Given this list of marker genes WDR11, SORCS2, SLC25A12 (NCBI Gene Id 8604), AUP1, UNC119, RAB3B, IL6, SRI, SLC18B1, KCNK1, VPS35L, SLC12A2, GHRHR, SLC1A2, SEC23B, CHMP2B, SLC6A15, YBX1, GIPC1, SLC49A4, SNX17, SLC6A11, SLC22A1, CHRM5, SP100, SLC11A1, LMTK2, TGFBR2, GCK, ADCY8, FAM53A, SCAMP2, AIFM1, PAM16, COG5, HTR2C, RAB11B, RGPD3, SLC25A31, ARL11, FOXA2, UQCC2, RPGR, KLHL20, WASHC2A, TARDBP (TAR DNA binding protein, NCBI Gene Id 81927), PRKCD, CENPF, RAB15, HEATR5B, NMD3, LIN7B, MIA2, EXOC4, RAMP1, SLC35A4, MTCH2, KPNB1, VIPAS39, SIX3, UBE2G2, RAB3D, REST, AIMP1, LRP5, ATP1B1, SAR1A, SLC25A18, EP300, SACM1L, RAB6C, RAB8A, FGB, CETN2, VPS39, SLC25A17 (NCBI Gene Id 10478), B3GAT3, SLC43A2, ACHE, RBM22, NEAT1, BEST1, MYRIP, HERPUD1, SMO, SLC38A6, SYT1 (NCBI Gene Id 6857), SELENBP1, PCK2, IFT56, GIP, VAMP2, GCKR, OAZ3, YIF1B, GCC2, CDKN2A, SLC16A10, NEUROD1, SLC7A6, LONP2, IPO7, AKTIP, NASP, SLC25A29, RANBP6, SNX32, BBS7, SMG1, MON1B, TOR1A, RBM8A, TRPM5, SLC52A3, JUP, EXOC7, MX2, SLC7A11, CHMP5, RAB11FIP5, VGF, CALHM4, TNFSF11, RAB11FIP3, ADRA2B, CRHR1, KIF3B, GLUD1, ARL5B, RABGEF1, AP1G2, LILRB1, APBA1, SMG7, FFAR4, PLEKHA8P1, RABL2B (NCBI Gene Id 11158), TMED1, NCOA4, RAB3IL1, ACVR2B, PRKN, NXF5, DENND1B (NCBI Gene Id 54530), TAP1, FMR1, GJA5, FRAS1, RBSN, VAMP4, SLC51B (NCBI Gene Id 123264), CHML, SLC25A25, STRADB, CDK5, HSPA4, AQP6, ORAI1, VTA1, MTNR1B, SLC7A1, PDPN, RAB8B, IGF2BP2, DOP1A, NPY2R, TMED5, RFTN1, PSAP, SNX7, SNX3, MYH10, GHRH, XPO1, KCNJ10, COG1, TRIM28, AP1B1, MCOLN1, STX18 (syntaxin 18), PANX1, F2R (NCBI Gene Id 2149), VMP1, MVP, ZDHHC2, SLC19A2, RBM33, NUP37, MIR130B, CNST, PCNT, SNX21 (sorting nexin family member 21), C17orf75, ZW10, ANK2, ARF1, NUP214, GDI2, ILDR2, PRKCE, FAM3D, GOLGA4, COPZ1, STX7, SARNP, OPRM1, ABCG2, UCN, ZFAND2B, NECAB3, NEURL3, MYO7A, QKI, MLPH, ARFGAP2 (ADP ribosylation factor GTPase activating protein 2), GPR89A, TMED2 (NCBI Gene Id 10959), RAB6B, ARL17B, ELAVL1, MAFA, RGPD1, SFXN3, AHCYL1, NHERF1, ARL3, OXCT1, SLC7A3, MVB12A, SLC23A3, SLC9B2, TMED3, TIMM10, SERINC3 (serine incorporator 3), RAC1, CNIH4, TRAM2, SLC6A3, MCOLN2, ARHGAP1, RAB14, RINT1, ITGB3, SEM1, SEC62, ZC3H12A, LARGE1, DUOXA1, EIF4A3, S100A13, APOE, HBA1, TOMM20, TANGO6, LYPLA1, JAKMIP1, PEG10, PER2, POM121L2, SLC9A4, GAPVD1, IPO5, RHBDD1, SYK, FYTTD1, NTSR1, LRRC8D, GRIPAP1, NXF2B, STX17, NUP98, AKAP8, EXOC2, POM121B, ZFYVE16, TSPO2, VPS45, DNAJC14, TGFB3, MTX1, NOS1, SLC6A6, SLC35A1, TBC1D17, PSEN1, MON1A (MON1 homolog A, secretory trafficking associated), FAM91A1, VPS13A, OAZ1, HERC2, CTNS, EXOC8, MGST1, RHCG, KCNB1, SLC25A53, B4GALNT2, TXN, KDELR1, MIR199A1, SLC38A8 (solute carrier family 38 member 8), TGFB1, KIF20B, RBP4, STX1B, TNPO2, SUFU, NXF2, NAGPA, UBAC2, GLTP, STX16, CCDC93, PLA2G3, AACS, TMED10, SLC1A5, SLC25A20, SLC6A9, TIMM21, MIR29B1, TREM2, TRIM23 (NCBI Gene Id 373), PDCD6IP, HTR1A, ECRG4, AGAP1, PLEKHF2, SAA1, SLC35C1, P2RY1, WASHC2C, MAPK15, CHRNA4, CTAGE9, CHMP4B, TERT (telomerase reverse transcriptase), ITPR1, ADAM8, NUP160, FOXO1, PEX19, FERMT1, TUNAR, TUBA1A, TCN1, XPO6, SLC38A2 (solute carrier family 38 member 2), FGG, CAMK1, TFR2 (transferrin receptor 2), EXOC6 (exocyst complex component 6), PEX1, MTM1, DDX25, ATG3, PAX8, CLEC4M, ZC3H11A, PFKM, RAB39A, HDAC6, SLC25A51, ISL1, HLA-DRB1, SEC16A, EXOC6B, ADORA3, C2CD2L, VPS51, IFT25, SLC7A6OS, RAB41, MYO1D, DRD3, MIR199B, UHMK1, RAB11FIP2, RAN, TMEM167A, TMEM129, PLA2G1B, APBA3, PPP3CA, CALHM5, ZIC1, SCG5, VPS26A, SPRN, HNF1B, DRD2, TLR4, ATF2, VPS16, RGS4, MIR128-1, STX10, TRMT10B, ATP8A1, ANGPT1, ACTN4 (actinin alpha 4), COPG2, SLC38A9 (solute carrier family 38 member 9), WASHC5, TOMM40, SYT11, E2F3, SLBP, SNX14, PRP4K, CETN3, TOMM5, TOM1L1, TNF, PARK7, SLC7A8, ABCB7, SLC28A1, HBB, VPS41, CLSTN3, VPS29, SLC17A2 (solute carrier family 17 member 2), TRIP11, SLC6A8 (solute carrier family 6 member 8), IPO8, TIMM17A, LRRC8A, CHRNA6, RHAG, NF1, AFG2B, UPF2, ATP13A4, DERL1, SIRT3, THOC5, EMD, SLC5A7, ADRA2C, CASR, SLC15A1, AMN, LRP2, INS, DENND2A, MMP7, ARFGAP3, CD24, SLC18A2, TVP23B, TRPM4, MIDN, SLC28A3, SLC23A1, KHDRBS1, TMED7, SLC25A23, KPNA3, MYH9, HNF1A, SLC7A9, ZC3H11C (zinc finger CCCH-type containing 11C), MDM2, NEURL1B, EXOC1, OPRK1, NR1H3, DRD1, PPID, CCDC186, GRK2, SLC36A4, LYN, GNA11, RAB27B, SLC29A1, SNUPN, SLC16A12, TNPO3, VPS37C, IL10RA, MAMDC4, CRH, ACSL3, NAPA, KIF5A, CD320, TPR, BBS1, TMEM30A, FUT10, RANBP3L, ACSL4, PPARG, GPM6B, SNCG, AP3S1, RAB44, VAMP7, ATG4C (autophagy related 4C cysteine peptidase), DYNLT1 (NCBI Gene Id 6993), UFM1, KRT20, BBS2, CAV1, AP3B2, SNX25, GOPC, RTN2, NUP54, PCSK5, NTRK2, AKAP5, VPS54, ABCA13, VPS25, CORO7, MFSD1, GNAO1, FGF9, SCARB2 (scavenger receptor class B member 2), AP3S2, SUCNR1, DERL3, CHCHD4, SLC16A1, RPH3A, SLC44A2, KPNA5, CDK1, COPB2, ARF4, SLC1A7, RD3, LCA5, SUPT6H, PKD1 (polycystin 1, transient receptor potential channel interacting), PLCB1, ERP29, KPNA4, TGFBRAP1, ARHGEF2, SLC35B3, TOMM70, RAMP2, PHAF1, FXR1, AP3M2, COL1A1, ABCC2, SLC25A38, SPTBN1, SLC3A2, NOTCH1, RAB3GAP2, PKIG, RAB12, AP2A2, SYT4, EXOC3L1, WASHC4, ATXN2, ABCC6, DNAJC19, GNPTG, UPK3A, SYNDIG1, ARFGEF2, GRP, CAMSAP3 (NCBI Gene Id 57662), CCDC22, HEATR3, APP, NNAT, RAB29, NACA2, TIMM29, SNX27, AGFG1, COPB1, TESC, FFAR3, SPG11, RAB4B, RABGAP1L, CEP290, SLC16A9, ARC, NKX6-1 (NCBI Gene Id 4825), CHMP1A, SLC7A5, HSPB1, ACTB, ARCN1, RTRAF, RGS2, SIX2, FRMD4A, CHGA (NCBI Gene Id 1113), APBB1, CLN8 (CLN8 transmembrane ER and ERGIC protein), ATG10, MACIR, ARL4C, PGAP1, BLOC1S3, CLTRN, DTNBP1, SCRIB, BTK, COMMD1, PEX2, SPIRE2, RAB32, CBLN1, SLC22A16, ZG16, STX8, CFTR, RIC1, SFT2D3, WASHC3, SH3TC2, CTTN, GOSR2, ABCA1, EDNRB, SCAMP4, IST1, FLNA, CHM, IL13, SYNRG, PTPRN2, TMEM115, BTF3, ASPH, ARL6IP1, GAL, MDFIC, ARL4D, SEPTIN8, EHD1, NUP62CL, SLC25A52, POM121C (NCBI Gene Id 442581), PEX6, VEGFC, PDX1, SYTL1, CLTA, GRM1, SNX15, SLC36A3, DHX9, NOS2, PPM1F, ATP11A, ATP2C1, GGA1, SEC24C, BBS9, AQP3, CALR, RAB1A, GNAI1, AZGP1 (NCBI Gene Id 90053), TAF7, LLGL2, PTPN1, DNAJC27, CXCL12, NPY5R, IL1B, SLC46A2, PRF1, NUP153, CD33, SNX11, CTAGE15, STXBP1, ATP6AP1, SLC25A19, HSPA5, MAP1A, CERT1, HPSE, SLC25A36, ARL8A, INHBB, P2RX7, RFTN2, ATP8A2, SPAG17, DISP1, CD200, SLC19A1, TMEM97, IFIT1, GCG, KCNN4, FGF20, TRPC4 (NCBI Gene Id 7223), AP1M2, AP2M1, LRSAM1, PDE8B, SLC35A3, GRPEL1, ABCD2, SHOC2, FLOT1, SNX8, RAE1, HIKESHI, ATG4A, RAB19, PRKCB, BET1, CALHM2, FCER1G, JAK2, ABCC5, PCM1, PKDCC, RAB26, RAB4A, CBLIF, GPR119, COG7, RILPL1, CBLN4, EDNRA, DUOXA2, ZFP36L1, HMGA2, RILP, SLC52A2, SLC4A8, ERC1, CHMP4C, RAB36, TGM2, SYTL2, PTPN23, PEX5L, DERL2, SLC38A1 (solute carrier family 38 member 1), CSF2, MIR146A, CR1, KLF7, COPA, MC4R, NEDD4, SCG2, SORL1, STXBP2 (NCBI Gene Id 6813), PEX12, PEX26, TSG101, MIR30C1, COG3 (NCBI Gene Id 83548), CASC3, RAB6A, CLIP3, CRHBP, SNX30, NACA, CALHM1, SLC26A6, ZFAND1, DGKD, ADCYAP1, ABCA12, NR4A1, VPS33B, IL33, MAPK14, TSC2, RAB28, SLC22A15, NEO1, ALKBH5, TM7SF3, ABCC1, HYAL2, VPS8, RAB10, RAB39B, GPER1, TRPV4 (transient receptor potential cation channel subfamily V member 4), STX3, MIR19B1, CHMP2A, FAM3B, SCAMP3, USP9X, ARFIP2 (NCBI Gene Id 23647), CYB5R4, EHBP1, SLC22A4, EXOC3, C2CD5, DNAJC15, GOLT1A, SORT1, NBAS, VPS18, RAB5A, GABBR1, KPNA7, RAB11FIP1, DNAJC1, SEC61A2, ADIPOQ, ABRA, NUP42, SETD2, PAFAH1B1, SNX5, HSPA8, UMOD, RAB7A, GOLPH3L, RANBP2, RCN3, COPZ2, RAB38, ZFP36, SLC1A3, PFKFB2, SLC35D1, KCNA5, SMG5, PORCN, WNK1, SQSTM1, SURF4, TRPV1, ARFIP1, SYS1, CTAGE4, AGK, RAB2B, SLC25A41, KCNK16, NDP (NCBI Gene Id 4693), KIF17, CHMP3, NUP50, EPM2A, GNAT1, VPS37A, CDKN1A, MLXIPL, STAT3, SLC25A24, GRIP1, SLC14A1, NPIPA1, PRKG1, COMP, NR1H2, YOD1, COG2, GFER, HIP1, ENSA, GABARAPL2, MYO18A, TIMM9, ARRDC2, RSAD2, RAB18, PPARD, PIM3, IGF2BP1, TSNARE1, AP1AR, EPHA5, CHP2, SVIP, PPT1, SIRT6, CWH43, SLC15A5, GRPEL2, P3H1, BCL3, THOC6, COPG1, SNX18, NGFR, SLC12A5, MMP12, RGPD6, CD81, SEC31A, GPLD1, EXOC5, RACK1 (receptor for activated C kinase 1), IRS1, ATP13A1, XPO5, CD63, SLC22A14, TIMM50, ANK3, SEC63, SLC7A14, GJA1, TIMM22, CTAGE6, ATG4D, ATP11B, HDAC3, LIN7C, AGAP2, SLC25A33, TCN2, SLC25A40, CLTCL1, SLC7A7, SLC44A4, RHCE, HNF4A, BBS5, FMN2, AHCTF1, NUP43, RABIF, SLC25A13, SLC66A1, SIDT1, CPLANE2, SLC17A3, RGPD2, SCT, TNKS, RANGRF, SREBF1, RAB1C, TCIRG1, CLU, C1QTNF12, FKBP1B, TIMM23B, ANXA13, AP5S1, PHB2, TOMM6, BLOC1S6, SLC5A6, ILDR1 (NCBI Gene Id 449482), BMP6, DMAP1, ABCC4, TMEM132A, SLC18A3, ICE1, CMTM6, VAMP8, RALBP1 (ralA binding protein 1), ARL8B, ERGIC3, VPS4B, SLC35A2, MYO6, RPAIN, FOLR1, GAS6, PEX5, DAG1, SLC25A44, LUZP4, SEC24B, AP3M1, HTR1B, NR0B2, DTX3L, CPT1A, SNX12, OAZ2, GDI1, PPP3R1 (NCBI Gene Id 5534), FAM76B, RAB25, LRRC8E (leucine rich repeat containing 8 VRAC subunit E), TIMM8A, DDX19A, NUP62, SLC44A5, SLC6A4, PEX7, NPM1, RHBDF1, SAR1B, PSMD9, EPG5, TMEM30B, OSBP, VAMP3, SEC61B, UNC13B, TFAP2B, AAGAB, CCDC91, ARL4A, NAPG, VSNL1, ANP32B, RPH3AL (rabphilin 3A like (without C2 domains)), TRARG1, LRRK2, NDUFA13, MIA3, TBC1D5, HAP1, VPS52, ABCD1, EIF4E, APPL2, RIPOR1, SLC18A1, TCF7L2, ADTRP, ZDHHC17, EIF4ENIF1, TAP2, CALHM6, STXBP4, STEEP1 (NCBI Gene Id 63932), GHSR, XBP1, RASL10B, AP5B1, RBM15B, FRAT1, PEX10, CABP1, EHD3, LMNA, MSR1, SLC5A8, GBF1, RAB3A, SLC6A1, SEC13, POM121, ABAT, GABARAP, SLC25A42, ARRDC4, GOSR1, TOR2A, PPP3CB, CD36, TOMM20L, LRP1, RAB2A, RBFOX1, EIPR1, STRADA, MTCH1, ARF6, ZPR1, SYT7, COG6, SEC22C, SLC6A7, EFCAB7, GNAT2, SELENOS, ELMOD3, CADPS, CHP1, SLC22A13, LYST, STXBP3, IRGM, HSPD1, SNX2, ADORA2A, AQP9, NUP35, UBAP1, PEX13, ARF3, CTDSPL2, NMU, KTN1, RAB7B, SHH, COMT, MECP2, GRM7, SLC15A2, CFL1, NETO1, CPTP, C1QTNF3, RAB11A, SEPTIN2, TRIM37, BLZF1, PREB, SNAP29, CHRNB2, RAB5B, RAB17, C1QTNF5, SNX1, CD3G (NCBI Gene Id 917), FUZ, TIMM23, SLC6A20, RAB20 (NCBI Gene Id 55647), STK4, TLR2, ANKH, TRPA1, UBE2J1, NUP93, GPR89B, ATP11C, HNRNPA2B1, CSE1L (NCBI Gene Id 1434), THOC3, NUP88, RBM4 (RNA binding motif protein 4), CUBN, SLC33A1, PDZK1, SLC25A39, SNX22, PGRMC2, UBR5, YWHAH, SLC1A4, PRKACA, RIMS2, SLC25A26, RAB9A, FCHSD2, HPX, HHEX, ARL6IP5, DRD4, ABCB6, GOLGA2, XPO7, SFT2D1, REEP2, EDEM2, SLC29A3 (solute carrier family 29 member 3), PGRMC1, ERLEC1, PARD6A, KRT18, SNX20, NDC1, AFTPH, GOLGA7, AP1G1, FFAR1, PARP11, RAB6D, AVPR1A, SNX33, POU3F3, TRAM1L1, EDEM1, SLC38A4, CPLX1, YIF1A, STX6, GOLT1B, SLC7A10, SFN, ZFAND6, SRPRA, BECN1, BAIAP3, RAF1, SMAD2, CCHCR1, KHSRP, PEX3, BCAP31, SEC14L1, CKAP5, CPSF6, CBLB, NACAD, TTYH1, SPIRE1, MAPK8IP3, SLC6A13, VPS28, HSF1, FLVCR2 (NCBI Gene Id 55640), NPLOC4, FRMPD1, RAPGEF3, STK3, SMURF1, DENND4C (NCBI Gene Id 55667), ARRB2, ADCY10, SLC44A3, SLC15A4, ADAMTS9, TTN, ENTR1, KIF13A, BICD2, PRICKLE1, NFE2L1, IFI27, UPF3A, PRKD1 (NCBI Gene Id 5587), AP1S3, VIP, UCP2, SLC46A1, AP4E1, SELENOT, PFKL, PABPN1, SLC28A2, PRKCA, STAM2, FAM3A, STX4, MACF1, AQP7, RAB21, MAVS, SLC29A4, NUP205, WWP2, CLSTN1, RAB24, PHAX (NCBI Gene Id 84137), BBIP1, HIF1A, PLEKHA8, SLC25A15, SMAD3, UBE2Q1, GLP1R, SYTL4, NUP210, ATG16L2, PEX16, SIRT4, MBTPS1, FAF2, SNX13, SCAMP5, ANKRD1, ACVR1C, GORASP1, THOC1, KIF20A, SLC38A5, NUP85, SMG6, LRRC8B, NPFF, NOL6, BET1L, TECPR2, APOBEC1, DESI1, IDH2, CD38, ZC3H3, NUP155, LMAN2L, RAB33B, TMED9, USO1, ADAR, PPY, LTBP2, BARD1, GPRC6A, PRAF2, AQP1, TP53, APPL1, DYNLL1, RAB3GAP1, RAB13, UPF3B, CALHM3, STXBP5, RFX6, ATG16L1, AAAS, CHRNA3, ARF5, IL12A, XPO4, NPAP1, MCFD2, BCR, RUFY3, VPS26C, SLC16A6, VDAC3, BMP4, DDX19B, AKT1, ACE2, SLC25A4, CLN3 (CLN3 lysosomal/endosomal transmembrane protein, battenin), AFM, RANBP3, SOX4, BMAL1, SLC35B4, PIK3R2, STXBP5L, SLC14A2, TACR2, TRIM3, CD74, SLC66A1LP, RUFY1, CDH1, FGA, HCAR2, SLC36A2, ECT2, SLC6A14, SELENOK, SRSF7, DENND1A, M6PR, SRP54, RGPD8, AP4S1 (adaptor related protein complex 4 subunit sigma 1), DNAJC13, PLA2G6, AQP11, TRH, YWHAB, SLC22A12, RHD, ACAP1, ASTN2, NDFIP1, GPR68, NCBP1, MICALL1, RFFL, CTSA, EDN1, SEC24D, F2RL1, SNX6, NR1H4, WASHC1, ARRDC5, LMAN2, RAPGEF4, HNRNPA1L2, SLC6A2, EFNA5, MFSD12, GIPR, CHMP4A, GSDMD, AP1S2, KCNQ3, RHBDF2, KCNK2, KDELR3, HSP90B1, MAGOH, SSB, TRAF3IP2, KMO, SEC22A, GRM2, AP3B1, MPC2, NUP107, PDIA4, SLC43A1, NSUN2, S100A8, CA2, HOOK2, CLOCK, ATP13A5, VPS13C, SFT2D2, PLEK, FRAT2, RHBDD3, PINK1, DDX39A, RGPD5, SLC2A2, ENY2, UCN3, NXT2, FXR2, VTI1B, SEC31B, ABCB1, G6PC2, TOM1L2 (NCBI Gene Id 246315), RRBP1, RAB31, NUP133, TIMM44, SLC35B2 (NCBI Gene Id 347734), TRAM1, NECAP1, SLC22A2, CELA2A, REP15, MCM3AP, HNRNPA1, AZIN2, CHMP6, SLC6A12, FAM53B, GPR27, TXNIP, AKAP8L, STAM (signal transducing adaptor molecule), SLC35C2, VPS35, PTPN11 (NCBI Gene Id 84990), SLC1A6, GFAP, APBA2, ARHGAP44, FAM53C, ASPSCR1, CAPN10, POLA2, APPBP2, TNPO1, KIF5B, VPS4A (vacuolar protein sorting 4 homolog A), SLC35A5, GGA2, CEP131, RAB3C, RABEP1, ARHGAP33, SCAMP1, GSK3B, EI24, CALCRL, LRRC7, IPO4, FKRP (NCBI Gene Id 79147), KCNJ11, ABCG1 (ATP binding cassette subfamily G member 1), ARL1, TMED6, EPS15, TMCO6, PRKAR1A, CDK16, KPNA1, AVP, AKIRIN2, STX5, TMEM9, DMBT1, SLC32A1, YIPF5, PLTP, ALYREF, SYTL3, NXF3, NXT1, BBS4, B3GLCT, VPS37D, NDUFAF2, SLC25A16 (solute carrier family 25 member 16), RAB43, TFRC, RAMP3, IL1RN, ABCB9, BAD, SLC25A32 (NCBI Gene Id 81034), F2, GLI3, ANKRD50, TMED4, PCLO, ATP8B1, RTBDN, PML, APBB3, ANKLE1, NFKBIA, EGR2, SNX24, BRSK2, RAB37, TLK1, MYOM1, SLC17A9, BLK, SLC17A8, SLC17A1, ABCD4, TGFB2, AP2A1, PICK1, RABL2A, SLC7A2, ADAM9, MIR301B, SLC30A8, PPIA, SLC1A1, SEC22B, SLC7A13, CARTPT, NSG1, SLC26A7, SLC25A6, VPS26B, ALOX5, SLC25A5, RSC1A1, AP4B1, TOM1, ITGB1, THOC2, AP2B1, SFXN1, SLC43A3, DNM1L, ABCC11, APLN, CTAGE8, TTYH3, RAP1GDS1, SLC16A2, SEC23A, SLC22A5, MCU, RHOB, SYBU, SLC25A2, FFAR2, MIR148A, PPM1A, PTPN14, GNPTAB, DPH3, CAVIN1, GUK1, NECAP2, SCFD2, MVB12B, KDELR2, RAB3IP, SERP1 (NCBI Gene Id 27230), CD2AP, PREPL, PPP1R10, ATG4B, RANGAP1 (Ran GTPase activating protein 1), TANGO2, SDAD1, SYTL5, ANG, BAG3, CPLX3, SLC17A6, SGPP1, NAPB, SNAP23, FLVCR1, YTHDC1, SLC25A22, DNLZ, ATG14, DENND10, SCFD1, SLC17A4, PDCD6, KIF3A, SLC6A5, CACNB4, SNX16, NUP188, TTYH2, AP4M1, SLC13A3, STEAP3, CHRM1, HOOK3, ATP13A2, ANKRD27, ABCA2, PNPT1, RABL3, MLC1, CCL5, MAP1LC3C (NCBI Gene Id 90303), SNX19, LYPLAL1, SDHD, SLC52A1, SLC2A9, SLC35D3, NLGN2, PIK3R4, ANO1, IGF2BP3, PASK, STX19, NSF (N-ethylmaleimide sensitive factor, vesicle fusing ATPase), SEH1L, CYP51A1, SLC3A1, VPS53, SLC19A3, LRPPRC, FHIP1B, SNX10, AQP8, SLC7A5P2, PRR5L, LRRC8C, VPS36, CHMP7, FUT11, CTAGE1, RFX3, PTTG1IP, SLC35B1, PIANP (PILR alpha associated neural protein), EIF2D, MRPL18, ARHGEF5, SIL1, TVP23C, CLTC, HBA2, TM9SF4, SLC44A1, CBL, NR1D1, RP2, JAGN1, IFT22, GDNF, VTI1A, RAB35, AP5Z1, TOMM22, NRDE2, MIR93, RAB5C, ABCC8, SEC61G, CADPS2, STX2, LMAN1, GHRL, SUMO1, YWHAE, C12orf50, KPNA2, SNCA, HMGCR, SNX31, IPO11, MED1, FOLR3, PHPT1, SNAP25, SNAPIN, AZIN1 (NCBI Gene Id 51582, antizyme inhibitor 1), ATG7, ADCY5, VLDLR, SNF8, SLC17A7, CHD7, LEP, IL12B, SERINC5, SLU7, RABEP2, PIK3C3, MYO5A, HTR2A, INSIG1, PLK3, SEC23IP, DOP1B, IFT20, IGF1, SLC35D2, ARRDC3, ARFGEF1, TBC1D13, AP1S1 (adaptor related protein complex 1 subunit sigma 1), EXPH5, OPTN, ATP1A2, TENM1, ATP13A3, PDCD10, RAB27A, TST, TMEM241, SLC47A1, VPS11, VPS50, SNAP91, CSK, LRP1B, TOMM7, APOD, AP3D1, TIMM17B, ARL6, ARL5C, CDH17, ARRDC1, PEX14, VAPA, GPIHBP1, FOLR2, SEL1L, PCID2, IPO9, GGA3, CPE, XPOT, ADRA2A, STX11, SNX4, UNC119B, IER3IP1, NXF1, SLC38A7, POLDIP3, GRIP2, IL1A, ARRB1, ARL5A, WLS, HSP90AA1, TIMM8B, EDN3, YKT6 (YKT6 v-SNARE homolog), SLC48A1, F2RL2, CRYZL2P-SEC16B, ELMOD1, ZMAT3, HSPA9, MAGOHB, SLC36A1, TOMM40L, RILPL2, RAB9B, SIDT2, VCP, SRSF1, MCL1, SLC15A3, MON2, SRSF3, VPS37B, SSTR5, SLC38A3, AP2S1, TVP23A, SLC8B1, PIK3R1, ITSN1, CHTOP, IPO13, DLG2, ARFRP1, LSG1, BMP8A, CD209, HADH, NUTF2, CANX, KCNA2, LAMP2, DNAJA1, VAMP5, SLC38A11 (solute carrier family 38 member 11), NUP58, LCP1, KPNA6, RAB23, NCBP2, SEC61A1, ZC3H11B, P2RX1 (NCBI Gene Id 5023), AP5M1, OLFM2, B2M, SIRT7, TIMM10B, STX1A, KIF18A, SAMM50, MIR766, GNAZ (NCBI Gene Id 2781), SLC29A2, SVBP, RHBG, HOOK1, MIR19A, OS9, RAB34, NDEL1, CLTB, ABCB4, SLC25A47, PTPRN, MYO5B, COPE, STX12, TIMM13, USE1, HCLS1, IFT27, MTX3, RIMS1, DDX39B, THOC7, SLC6A17, LIN7A, CEP41, ACD, CCN3, ARL14, UEVLD, RGPD4, HCN2, SLC7A5P1, TTC8, CAMK2G, GLTPD2, UFD1, MTTP, HM13, ADORA1, BCAP29, SLC38A10, NADK, SLC35F3, ARFGAP1, VPS33A, IRS2, COG8, LMF1, SERGEF, NDFIP2, ROMO1, RPL23, HGS, UNC93B1 (NCBI Gene Id 81622), KCNJ8, BSG, DAB2, UPF1, SEC16B, ZBED6, ING1, DNM2, GLE1, RAB1B, COG4, SLC35E3, SYVN1, SEC24A, LAPTM5, RAB22A, VPS13D, DOC2B, CD47, SLC22A3, SMPD3, PLEKHM1, KIF5C, GOLPH3, MTX2, SFXN2, IWS1, SENP2, HPS6, PITPNM1, RINL, G3BP2, CHMP1B, CHRM3, GNAS, NCBP3, AP1M1, WASH3P, HFE, SNX9, SLC27A1, RANBP17, IFNG, OXT, APOB, CRY2, OR51E2, PKIA, here is a description of the gene set: The directed movement of nitrogen-containing compounds into, out of or within a cell, or between cells, by means of some agent such as a transporter or pore. Human Gene Set: GOBP_NITROGEN_COMPOUND_TRANSPORT species: Homo sapiens